The following is a description of a gene set: studied in species Homo sapiens Human Gene Set: GOBP_BONE_MORPHOGENESIS The process in which bones are generated and organized., and this is the list of marker genes: IFT80, CYP26B1, RARG, NAB1, NPR2, SERPINH1, IHH, NPPC, PEX7 (NCBI Gene Id 5191), STC1 (NCBI Gene Id 82914), BPNT2, BMPR2, MEF2C, LTF (lactotransferrin), BMP6, RARA, GLI3, ATG9B, FGFR3, EXT1, BMPR1B, INPPL1, GHR, LRP5, SCX, TWIST1, INSIG2, TMEM107, MMP16, RARB, POR, TIFAB, TGFBR2, THBS3, COMP, NEUROG1, FOXN3, ACP5, CER1, PHOSPHO1, ACTN3, BMP4, COL13A1, CHSY1, DCANP1, IFITM5, HOXA11, SMPD3, RUNX2, RAB23, AXIN2, TFAP2A, MMP13, TRIP11, TGFB1, SKI, TRPV4, COL3A1, CSGALNACT1 (chondroitin sulfate N-acetylgalactosaminyltransferase 1), SOX9, COL2A1, HAS2, NAB2, SFRP4, ATG9A, CBS, MATN1, ZMPSTE24, SHOX2, RIPPLY2, ALPL, EXT2, INSIG1, FGF4, POC1A, MSX1, DHRS3, FGF18, FOXC1, FOSL2, TMEM119, COL27A1, CITED2, MSX2, FGFR2, SP5, MEGF8, ATF2, ENSG00000274276, GALNT3, GLG1, DLX5, TSKU, LTBP3, FREM1, MMP14, PAPPA2, CDX1, COL1A1, OSR2